Given this list of marker genes CNP, MAPK12, THRA, BMP4, FGFR3, PTH1R, FGF9, MAPK13, MAPK11, CDKN1A (NCBI Gene Id 1026), SOX9, IHH, MAP2K1, MAPK14 (NCBI Gene Id 1432), RBL1, MAPK1 (NCBI Gene Id 5594), MAPK3, SNAI1, BMP2, MAP2K2, NPR2 (NCBI Gene Id 4882), STAT1, RAF1, FGF18, PPP2CA, PTHLH, ATG5, here is a description of the gene set: Human Gene Set: WP_FGFR3_SIGNALING_IN_CHONDROCYTE_PROLIFERATION_AND_TERMINAL_DIFFERENTIATION studied in species Homo sapiens FGFR3 signaling in chondrocyte proliferation and terminal differentiation